The following is a description of a gene set: studied in species Mus musculus The component of a plasma membrane consisting of gene products and protein complexes that are loosely bound to one of its surfaces, but not integrated into the hydrophobic region. Mouse Gene Set: GOCC_EXTRINSIC_COMPONENT_OF_PLASMA_MEMBRANE, and this is the list of marker genes: Cabp1, Traf6, Sarm1, Arap1, Cdhr18, Ctbp1, Cdh19, Cdh4, Crkl, Gna13, Ctnna1, Rab13, Gnas, Gng12, Olfm1, Gng5c, Olr1, Snap25, Gnai3, Jak2, Cdh24 (NCBI Gene Id 73311), Dnajc6, Nptx2, Gnb1, Mcf2l, Cdh23, Gna11, Farp1 (FERM, ARH/RhoGEF and pleckstrin domain protein 1), Cdh7, Snap91, Gnai1, Ppl, Ap2b1, Apc2, Cnr2, Cdh22, Gng14, Arsa, Cdh10, Ctnnd1, Cdh11, Gngt2, Ank2, Dgkb, Nbea, Gng3, Cnksr2, Myd88, Gnao1, Ctnnb1, Cdh3, Magi2, Rnf10, Gng13, Cdh12, Tiam1, Cdh9, Fgf22, Gnal, Gnb3, Gna14, Gna12, Gngt1, Gnat2, Gng5, Plekha4, Gna15, Apoe, Vwc2, Picalm, Cdh1, Gng2, Gnb5, Cyth2, Art2b, C1qa, Scrib, Nod2, Dtna, Cdh2, Ap2m1, Tenm2, Gng7, Ppp1r9b, Cdh26, Cyth1, Ap2s1 (adaptor-related protein complex 2, sigma 1 subunit), Cdh8, Apc, C1qb, Dchs1, Vinac1, Scube2, Stxbp1, Atp2a2, Gnb4, Tgm3 (transglutaminase 3, E polypeptide), Cdh18, Jup, C1qc, Jak1, Phb1, Dgki, Gnat3, Cdh17, Cdh13, Cdh5, Ryr1, Rims1, Ryr2 (ryanodine receptor 2, cardiac), Gng10, Gng8, Gnai2, Tirap, Cdh20, Olfm2, Gphn, Gnaz, Gnb2, Ctnna2, Gnaq, Gnat1, Akap9, Gng4, Cdh15 (NCBI Gene Id 12555), Cdh6, Stxbp5, Fbxo2, Jak3, Gng11